The following is a description of a gene set: from publication Fu W, Ergun A, Lu T, Hill JA, Haxhinasto S, Fassett MS, Gazit R, Adoro S, Glimcher L, Chan S, Kastner P, Rossi D, Collins JJ, Mathis D, Benoist C (PMID 22961053) Genes down-regulated in CD4 T conv over-expressing SATB1 versus SATB1 and FOX3P. The transcription factor FoxP3 partakes dominantly in the specification and function of FoxP3+ CD4+ T regulatory cells (Tregs), but is neither strictly necessary nor sufficient to determine the characteristic Treg transcriptional signature. Computational network inference and experimental testing assessed the contribution of several other transcription factors (TFs). Enforced expression of Helios or Xbp1 elicited specific signatures, but Eos, Irf4, Satb1, Lef1 and Gata1 elicited exactly the same outcome, synergizing with FoxP3 to activate most of the Treg signature, including key TFs, and enhancing FoxP3 occupancy at its genomic targets. Conversely, the Treg signature was robust to inactivation of any single cofactor. A redundant genetic switch thus locks-in the Treg phenotype, a model which accounts for several aspects of Treg physiology, differentiation and stability. Human Gene Set: GSE40274_SATB1_VS_FOXP3_AND_SATB1_TRANSDUCED_ACTIVATED_CD4_TCELL_DN studied in species Homo sapiens, and this is the list of marker genes: STAC2, TRIT1, RNPC3, GABRB1, EFHC2, ZBTB41, SPNS3, LMO7, HSF4, PDS5A, SNORD49B, SSH3, CRYGB, VEGFA, FAM78B, SCLT1, STX7, CCL2, ARC, ATP2C2, GDF10, LRRC19, DONSON, MYBPC2, NAXD (NAD(P)HX dehydratase), MEGF9, CDC42BPA, PGBD1, POLA1, CPNE3, CCDC38, FAM81B, TIRAP (TIR domain containing adaptor protein), ZRANB1, GABRA1, IFT57, MBD5 (NCBI Gene Id 55777), SKIL, AKNAD1, PPP3R1, TMEM150C, LNX1, ATP6AP1L, APOF, THUMPD1, GDPD2, DPH3P1, MMP13, SGO2 (shugoshin 2), IL13, DNAJB4 (NCBI Gene Id 11080), TMPRSS9, MAP3K19, SLC25A46, SLC1A7, ALMS1, ARMC3, KRTAP16-1, CHRM2, CHIC1, ID2, IFNL2, SOCS5, CCNY, ZNRF3, DAB2, BCOR, SLITRK6, EFNA4, NEIL3, CDCA7, MIR30B, MIRLET7G, STN1, MAPKBP1, KIF24, SIGLEC5, CXCL2, MRPS30, ITGB5, PRDM2, TMTC3, P2RY13, DHRS7C, RSPO3, FAM72A, NAT1, CD200R1L, SPC25, DEFB103A, KATNAL1, KIAA1614, MME, KCMF1, MAF, TMX1 (NCBI Gene Id 81542), CYSLTR1, INTS8, XRCC3, PSMG3, KIF13A, ZFP1, BIRC2, ERO1A, CST9, PRSS50, DUOX2, MIA2, TRIM2, FAM149A, DHRS7, EXOSC1, ABCE1, GALC, CNIH1, PPIL4 (peptidylprolyl isomerase like 4), COL3A1, TRIM42, SMC2, TBC1D12, ZCCHC7